The following is a description of a gene set: Mouse Gene Set: GOBP_LIPID_PHOSPHORYLATION The process of introducing one or more phosphate groups into a lipid, any member of a group of substances soluble in lipid solvents but only sparingly soluble in aqueous solvents. species: Mus musculus, and this is the list of marker genes: Dgkq, Dgkd, Dgkg, Dgki, Agk, Dgkb, Dgkz, Dgkh, Dgka, Dgke